The following is a description of a gene set: species: Homo sapiens from publication Cao J, O'Day DR, Pliner HA, Kingsley PD, Deng M, Daza RM, Zager MA, Aldinger KA, Blecher-Gonen R, Zhang F, Spielmann M, Palis J, Doherty D, Steemers FJ, Glass IA, Trapnell C, Shendure J (PMID 33184181) Marker genes curated from the annotated cluster as represented in the Descartes Human Gene Expression During Development database. Human Gene Set: DESCARTES_FETAL_SPLEEN_LYMPHOID_CELLS The gene expression program underlying the specification of human cell types is of fundamental interest. The study authors generated human cell atlases of gene expression and chromatin accessibility in fetal tissues. For gene expression, the study authors applied three-level combinatorial indexing to >110 samples representing 15 organs, ultimately profiling ~4 million single cells. The study authors leveraged the literature and other atlases to identify and annotate hundreds of cell types and subtypes, both within and across tissues. Our analyses focused on organ-specific specializations of broadly distributed cell types (such as blood, endothelial, and epithelial), sites of fetal erythropoiesis (which notably included the adrenal gland), and integration with mouse developmental atlases (such as conserved specification of blood cells). These data represent a rich resource for the exploration of in vivo human gene expression in diverse tissues and cell types., and this is the list of marker genes: IL23R, BLK, PARP15, TNFRSF13C, KLRC4-KLRK1, SPIB, CD27, CD247, POU2AF1, LARGE2, FCRL2, LINC01215, ANTXRLP1, LTA, ENSG00000266088, RASGRP1, SH2D1A, LY86-AS1, SAMD3, PHEX, CD3D (NCBI Gene Id 915), VAV3-AS1, KBTBD8, SHISAL2A, NCF1, FCRL1, PCED1B-AS1, CD8B, TAGAP, C1orf220 (chromosome 1 putative open reading frame 220), TMEM154, CD2, IGKC (NCBI Gene Id 3514), SLAMF6, ZNF860, EMB, CD79A, ENSG00000259097, C12orf42, IL9RP3, EOMES, KLRC1, CD52, VPREB3, ALOX5AP, CD5, COL19A1, CD8A, CCR6, PLAC8, MZB1, LINC00426 (NCBI Gene Id 102723372), LINC02968, CNR2, LY9, SLAMF1, DTX1, HSF5, SYTL1, IFNG-AS1, LINC01800, RN7SL337P, BCL11B, LINC02245, TNFRSF13B, AKAP5, CXCR5, ADAM7-AS1 (ADAM7, ADAMDEC1 and ADAM28 antisense RNA 1), SP140, STK17A, STAP1, IL2RB, FCRL5, LINC01588, TLR10 (toll like receptor 10), IFNLR1, CD37, CARD11, LINC00861, RN7SL842P, MS4A1, IGHM, SNX29P1, FCMR, SIRPG, GZMM (granzyme M), VNN2, LINC00926, THEMIS, HIP1R (NCBI Gene Id 9026), ADGRG5, CD3G, XCL1, GPR18, IGHD, CRAT37, ACAP1, IGLL5, PAX5, LEF1, LINC02397 (NCBI Gene Id 100508891), GPR55, LINC01222, IKZF3, CD96, BLNK, PLCG2, CR2, FCER2, NIBAN3, PYHIN1, LCK, SCML4, CCR7, LINC01891, PTPN22, CYFIP2, P2RY10, KLHL14, KSR2, KLRC2, ADARB2, NCR1, CD22, RHOH, RALGPS2, FCRL3, TIGIT, ALOX5